Given this list of marker genes YEATS2, SEMA4B, EYA3, RPS3A, FSBP, ACTR1B, OLFM3, ZNF133, CD5 (CD5 molecule), MFSD14A, EPN3, RAB27B, TJP2, MRPL30, ZNF879, TOB1, ID4, CTTNBP2NL, SAPCD1, UBE2D3, RFC1, TFDP2, FAM118A, SLF2, SORBS1, BRWD1, ZNF14, RAD54B, MAP3K14, GPR3 (NCBI Gene Id 2827), KMT5B, HS3ST5, LDLRAD3, MMP16, TMEM139, GYPE, THPO, HABP4, KMT2C, RPA1, USP15, SORT1, KIAA1549, CRTAM, SLC16A7, HDAC8, here is a description of the gene set: species: Homo sapiens Genes predicted to be targets of miRBase v22 microRNA hsa-miR-345-5p in miRDB v6.0 with MirTarget v4 prediction scores > 80 (high confidence targets). Human Gene Set: MIR345_5P from publication Chen Y, Wang X (PMID 31504780)